Given this list of marker genes Was, Unc93b1, Treml4, Trex1, Kdm5d, Icam1, Rftn1, here is a description of the gene set: species: Mus musculus Mouse Gene Set: GOBP_T_CELL_ANTIGEN_PROCESSING_AND_PRESENTATION The process in which a T cell expresses antigen (peptide or lipid) on its cell surface in association with an MHC protein complex.